Given this list of marker genes Nfkbia, Mfhas1, Sirt6, Sirt1, Trim40, Ufm1, Lzts2, Trim29, Tmem98, Cldn18, Sin3a, Pkia, Pkig, Dclk3, Hnf4a, App, Mark3, Ywhaz, Mdfic, Fbxo4, Dclk1, Ei24, Lats1, Fermt1, Akap1, Nf1 (neurofibromin 1), Cd36, Ywhab, Chp1, Polr1a, Apod, Otud7b, Ilrun, Dclk2, Lats2, Lilrb4a, Gsk3b, Cabp1, Maged1, Sumo1, Ctnna1, Angpt1, Lilrb4b, Rab23, Gbp4, Cdkn2a, Mtor, here is a description of the gene set: Any process that stops, prevents or reduces the frequency, rate or extent of protein localization to nucleus. species: Mus musculus Mouse Gene Set: GOBP_NEGATIVE_REGULATION_OF_PROTEIN_LOCALIZATION_TO_NUCLEUS